The following is a description of a gene set: studied in species Homo sapiens from publication Izadpanah R, Kaushal D, Kriedt C, Tsien F, Patel B, Dufour J, Bunnell BA (PMID 18519682) Human Gene Set: IZADPANAH_STEM_CELL_ADIPOSE_VS_BONE_DN Mesenchymal stem cells (MSC) derived from bone marrow stem cells (BMSC) and adipose tissue stem cells (ASC) of humans and rhesus macaques were evaluated for their cell cycle properties during protracted culture in vitro. Human ASCs (hASC) and rhesus BMSCs (rBMSC) underwent significantly more total population doublings than human BMSCs (hBMSC) and rhesus ASCs (rASC). The cell cycle profile of all MSCs was altered as cultures aged. hMSCs underwent an increase in the frequency of cells in the S phase at P20 and P30. However, rhesus MSCs from both sources developed a distinct polyploid population of cells at P20, which progressed to aneuploidy by P30. Karyotype analysis of MSCs revealed the development of tetraploid or aneuploid karyotypes in the rhesus cells at P20 or P30. Analysis of the transcriptome of the MSCs from early and late passages revealed significant alterations in the patterns of gene expression (8.8% of the genes were differentially expressed in hBMSCs versus hASCs, and 5.5% in rBMSCs versus rASCs). Gene expression changes were much less evident within the same cell type as aging occurred (0.7% in hMSCs and 0.9% in rMSC). Gene ontology analysis showed that functions involved in protein catabolism and regulation of pol II transcription were overrepresented in rASCs, whereas the regulation of I kappa B/nuclear factor-kappaB cascade were overrepresented in hBMSCs. Functional analysis of genes that were differentially expressed in rASCs and hBMSCs revealed that pathways involved in cell cycle, cell cycle checkpoints, protein-ubiquitination, and apoptosis were altered. Genes down-regulated in adipose tissue mesenchymal stem cells (ASC) vs bone marrow mesenchymal stem cells (rBMSC), and this is the list of marker genes: MYH10, SYTL2, RAB12, PBX1, SLC22A23, LTBP2, LAMB1, GATA3, HOXB6, FBN1, RGS4, AR, TXNIP, VCL, BCL7A, CISD1, LHX8 (NCBI Gene Id 431707), NDN, RIMKLB, FGF21 (NCBI Gene Id 26291), PPTC7, DOCK11, ARHGAP29, PRKAG2, FBLN1, CA12, EPB41L4B, ACKR3, LRRC17, N4BP2L1, DAB2, EN1, HYAL1, TPD52L1, LASP1NB, CDH11, FBXO32, PODN, CELF2, ID1, PLPP1, PCSK6, TNNC1, SST, CA11, COL5A2, KLHDC9, MFAP5 (microfibril associated protein 5), FAM234B, PPP4R4, MYH11, NFIB, SORBS2, ASAP3, NPR3, ANXA3 (annexin A3), IGF2BP3 (NCBI Gene Id 10643), STAT4, TLE1, MFAP4, PTGIS, HSPA2, CRYAB, EHBP1, SMAD1, DHRS3, FZD7, IGF1, SLPI, SLC29A1, JAM2, PIP5K1A, TMEM245, ZSCAN18, LAMA4, POSTN, GPRC5B (NCBI Gene Id 51704), S100A16 (S100 calcium binding protein A16), IRAG1, MEST, ASPN, PLOD2, NRIP1, MYH2 (NCBI Gene Id 4620), LOXL2, GPR87, LZTFL1, NEK1, SERPING1, CFB, SFRP2, KCNE4, NUAK1, KDM5B, AKAP12, AKR1C1, SLC24A3, LOX (lysyl oxidase), PRKCI, RTN2, ATP2B4, RASAL2, DAAM1, DHX40, TCF4, PALMD, CCDC80